Given this list of marker genes Slc8a1, Atp1a3, Slc4a4, Atp4a, Fxyd5, Atp4b, Agrn, Atp1a1, Fxyd3, Atp12a, Atp1b1, Fxyd4, Slc9a1, Fxyd6, Atp1b3, Atp1b2, Fxyd2, Fxyd1, Atp1a2, Nppa, Atp1a4, Fxyd7, here is a description of the gene set: Mouse Gene Set: GOBP_SODIUM_ION_EXPORT_ACROSS_PLASMA_MEMBRANE The directed movement of sodium ions from inside of a cell, across the plasma membrane and into the extracellular region. studied in species Mus musculus